Given this list of marker genes HPGD, CBR1, PPARGC1A, PTGS2 (prostaglandin-endoperoxide synthase 2), ANXA1, PTGFRN, PTGDS, EDNRB, S100A10, HSD11B2, PTGES, ANXA5, ANXA3, AKR1C2, PPARGC1B, AKR1C1, PPARG, ANXA8, PTGER1, ANXA6, S100A6, PTGS1, PTGDR (prostaglandin D2 receptor), TBXA2R, PTGER4, ANXA4, AKR1B1, HPGDS, CYP11A1, AKR1C3, SCGB1A1, MITF, PTGIS, PRL, EDNRA, EDN1, TBXAS1, ABCC4, ANXA2, PLA2G4A, PTGFR, HSD11B1, PTGER3, PTGIR, PTGER2, SOX9, here is a description of the gene set: Human Gene Set: WP_PROSTAGLANDIN_SYNTHESIS_AND_REGULATION Prostaglandin synthesis and regulation studied in species Homo sapiens